The following is a description of a gene set: Mouse Gene Set: GOBP_MONOCYTE_CHEMOTACTIC_PROTEIN_1_PRODUCTION The appearance of monocyte chemotactic protein-1 due to biosynthesis or secretion following a cellular stimulus, resulting in an increase in its intracellular or extracellular levels. species: Mus musculus, and this is the list of marker genes: Oas1d, Cd84, Oas1g, Cd24a, Oas1c, Mcoln2, Il1b, Ager, Nod2, Oas1f, Oas1e, Gstp-ps, C1qtnf3, Oas3, Gstp2, Trpv4, Oas1h, Kcnn4, Socs5 (NCBI Gene Id 69052), Selenok, Gstp3, Tnfsf18, Nr1h4, Erbin, Twist1, Hmgb1, Apod, Syk, Gstp1, Adipoq, Oas1a, Clec7a, Oas1b